Given this list of marker genes ME1, MDH1, MDH2, ME3, MDH1B, ME2, LIPF, PHGDH, here is a description of the gene set: species: Homo sapiens Catalysis of the reversible conversion of pyruvate or oxaloacetate to malate. Human Gene Set: GOMF_MALATE_DEHYDROGENASE_ACTIVITY